The following is a description of a gene set: species: Mus musculus Mouse Gene Set: GOBP_REGULATION_OF_RAC_PROTEIN_SIGNAL_TRANSDUCTION Any process that modulates the frequency, rate or extent of Rac protein signal transduction., and this is the list of marker genes: Dok7, Nf1, Ssx2ip, Stmn3, Kbtbd7, Dynlt1a, Crk, Dynlt1f, Kbtbd6, Dock2, Cadm4, Musk, Auts2, Agrn, Kras, Camk2d, Dynlt1c, Arhgap24, Pik3cb, Lrp4, Sh3bp1, Fnta, Tns3, Dynlt1b, Pik3cg, Gabarap (NCBI Gene Id 56486), Arhgap17, Arhgap44, Ogt, Rasgrf1, Dnm2, Crkl, Arf6, Rtn4